Given this list of marker genes CARD11, CEMIP2, PWP2, SQOR, IRAK2, ISCA1, REXO4, ZEB2, COG6, CDS1, ELAVL1, RPP38, HLA-DQB1, MECOM, SIK1, LANCL1, NDUFAF1, NEU2, GJA1, ARHGEF17, HLA-H, ENDOG, SSC4D, ARHGAP24, HYOU1, HLTF, SERPINB6, HLA-DQA1, here is a description of the gene set: Left ventricular mass (LVM) and cardiac gene expression are complex traits regulated by factors both intrinsic and extrinsic to the heart. To dissect the major determinants of LVM, we combined expression quantitative trait locus1 and quantitative trait transcript (QTT) analyses of the cardiac transcriptome in the rat. Using these methods and in vitro functional assays, we identified osteoglycin (Ogn) as a major candidate regulator of rat LVM, with increased Ogn protein expression associated with elevated LVM. We also applied genome-wide QTT analysis to the human heart and observed that, out of 22,000 transcripts, OGN transcript abundance had the highest correlation with LVM. We further confirmed a role for Ogn in the in vivo regulation of LVM in Ogn knockout mice. Taken together, these data implicate Ogn as a key regulator of LVM in rats, mice and humans, and suggest that Ogn modifies the hypertrophic response to extrinsic factors such as hypertension and aortic stenosis. Human Gene Set: PETRETTO_HEART_MASS_QTL_CIS_DN Down-regulated cis-regulated expression quantitative loci (cis-eQTL) in the heart that colocalize with previously mapped cardiac mass QTLs. studied in species Rattus norvegicus from publication Petretto E, Sarwar R, Grieve I, Lu H, Kumaran MK, Muckett PJ, Mangion J, Schroen B, Benson M, Punjabi PP, Prasad SK, Pennell DJ, Kiesewetter C, Tasheva ES, Corpuz LM, Webb MD, Conrad GW, Kurtz TW, Kren V, Fischer J, Hubner N, Pinto YM, Pravenec M, Aitman TJ, Cook SA (PMID 18443592)